Given this list of marker genes SLC17A7, SLC25A10, SLC5A5, SLC17A5, SLC17A8, SLC25A1, SLC5A8, SLC17A6, SLC25A22, SLC25A11, SLC25A18 (NCBI Gene Id 94012), SLC17A1, here is a description of the gene set: Organic anion transporters studied in species Homo sapiens Human Gene Set: REACTOME_ORGANIC_ANION_TRANSPORTERS